Given this list of marker genes CACNA2D1, CAV1, NEDD4L, MIR30D, RNF207, ADCY10, KCNA5, CAV3, MIR29B1, NOS1, AKAP6, SCN4B, KCNJ2, CACNB3, MIR133A1, FLNA, KCNE5, ANK2, NPPA, KCNIP2, SCN5A, AKAP9, CACNA1D, WDR1, KCNH2, ZMPSTE24, GJA5, YWHAE, KCNE3, CASQ2, KCNE2, SNTA1, SCN1B, MIR328, KCNQ1, MIR1-1, AKAP7, KCNE1, KCNE4, KCNH6, NOS1AP, here is a description of the gene set: Human Gene Set: GOBP_REGULATION_OF_MEMBRANE_REPOLARIZATION Any process that modulates the establishment or extent of a membrane potential in the polarizing direction towards the resting potential, usually from positive to negative. species: Homo sapiens